Given this list of marker genes RPS17, ADA2, RPL8, RPL26, RPS7, RECQL4, RPL15, RPL9, RPL18, RPL5, ANAPC1, HEATR3, GATA1, RB1, RPL35A, TP53, RPS26, LMNA, TSR2, RPS20, RPS27, RPS29, CDKN2A (cyclin dependent kinase inhibitor 2A), RPS15A, WRN, CHEK2, RPL31, RPS10, MTAP, RPL11, RPL27, RPS28, SQSTM1, RPL35, RPS19, MDM2, RPS24, here is a description of the gene set: Human Gene Set: HP_OSTEOSARCOMA Osteosarcoma A malignant bone tumor that usually develops during adolescence and usually affects the long bones including the tibia, femur, and humerus. The typical symptoms of osteosarcoma comprise bone pain, fracture, limitation of motion, and tenderness or swelling at the site of the tumor. species: Homo sapiens